The following is a description of a gene set: studied in species Mus musculus Thin, stiff, actin-based protrusion extended by the leading edge of a motile cell such as a crawling fibroblast or amoeba, or an axonal or dendritic growth cone, or a dendritic shaft. Mouse Gene Set: GOCC_FILOPODIUM, and this is the list of marker genes: Def6, B4galt1, Dnali1, Tubb3, Rdx, Myo10, Nherf1, Myo1b, Cdk5, Ripor2, Iqgap2, Nos1ap, Nlgn1, Enah, Fmr1, Cdc42, Ly6g6d, Ube2q1, Ninj1, Itga6, Morn4, Tenm2, Myo1g, Syne2, Myo5a, Kitl, Palld, Cib1, Ermn, Snap25, Tbc1d10c (NCBI Gene Id 74822), Twf2, Pdpn, Ube2k, Ngdn, Apbb1, Actc1, Srcin1, Ttyh1, Abi1, Twf1, Farp1, Gpm6a, Fzd9, Palm, Cd302, Rufy3 (RUN and FYVE domain containing 3), Map2, Ephb1, Osbpl3, Myo9b, Itga3, Fzd3, Itgb3, Unc5c, Myo3b, Cfl1, Acta1, Dmd, Vasp, Arl4c, Src, Dbn1, Itgav, Fscn1, Washc1, Rapgef3, Lrrc7, Utrn, Shtn1, Ppp1r9b, Npcd, Vcam1, Dync2i2, Abi2, Epha4, Cxadr, Baiap2, Fgd4, Tiam2, Trpv4, Ezr (ezrin), Ptprz1, Gap43, Fscn3, Ppp1r9a, Arf6, Myo3a, Inppl1, Antxr1 (anthrax toxin receptor 1), Cyfip1, Dync1h1, Dag1, Spef1, Crp, Actg2, Akap5, Myo6, Igf2bp1, Scimp, Kcnn3, Nf2, Vil1, Itgb1, Actn2, Fgf13, App, Lcp1, Ap2a1, Acta2 (actin alpha 2, smooth muscle, aorta), Mtm1, Podxl, Abitram, Acp3, Spata13, Adgra2, Fat1, Msn